Given this list of marker genes Mapk1, Grk2, Ripk2, Sphk1, Gsk3b, Wnk3, Met, Dgkq, Sirt2, Rptor, Cemip, Ogt, Cadm4, Cab39, Ppef2, Pard3, Phip, Stox1, Spred1, Spred2, Irgm1, Eif4g1, Igtp, Smad7, Ppp2r5d, Chi3l1, App, Egf, Plk1, Irgm2, Gsk3a, Inpp5k, S1pr2, Trim6, Tnks1bp1, Trpc5, Ube2k, Adcy10, Hnf1a, Wnt5a, Spry2, Dmtn, Trpc6, Ppp1r15a, Ttc36, Prkag2, here is a description of the gene set: studied in species Mus musculus Mouse Gene Set: GOBP_REGULATION_OF_PEPTIDYL_THREONINE_PHOSPHORYLATION Any process that modulates the frequency, rate or extent of peptidyl-threonine phosphorylation. Peptidyl-threonine phosphorylation is the phosphorylation of peptidyl-threonine to form peptidyl-O-phospho-L-threonine.